The following is a description of a gene set: This event has been computationally inferred from an event that has been demonstrated in another species.<p>The inference is based on the homology mapping from PANTHER. Briefly, reactions for which all involved PhysicalEntities (in input, output and catalyst) have a mapped orthologue/paralogue (for complexes at least 75% of components must have a mapping) are inferred to the other species. studied in species Mus musculus electronically inferred by orthology from the curated human pathway part of: Metabolism Reactome Pathway: Inositol phosphate metabolism, and this is the list of marker genes: Inpp5b, Aaas, Nudt10, Calm1, Ippk, Itpkc, Plcd3 (phospholipase C, delta 3), Isyna1, Ppip5k2, Plch1, Itpka, Ip6k3, Nup210, Nup155 (nucleoporin 155), Inpp5a, Itpk1, Minpp1, Inpp5j, Ocrl, Plcb3, Nudt4, Plcz1, Plcg2, Ip6k2, Inpp4b, Nup58, Plce1, Nup42, Nup205, Plch2, Nup133, Ndc1, Seh1l, Inppl1, Nup93, Nup54, Nup85, Nudt11, Ipmk, Ppip5k1, Rae1